Given this list of marker genes Gemin5, Sart3 (NCBI Gene Id 53890), Ddx39b, Prpf31, Prpf4, here is a description of the gene set: Mouse Gene Set: GOMF_U4_SNRNA_BINDING species: Mus musculus Binding to a U4 small nuclear RNA (U4 snRNA).